Given this list of marker genes RRP8, PHF8, BAZ2A, SIRT1, PHF2, BEND3, SMARCA5, MACROH2A1, SIRT2, DDX11, SUV39H1, here is a description of the gene set: Any process that results in the specification, formation or maintenance of the physical structure of nucleolar chromatin. species: Homo sapiens Human Gene Set: GOBP_NUCLEOLAR_CHROMATIN_ORGANIZATION